Given this list of marker genes FANCG, PTEN, RFWD3, DLL4, RAD51, GLMN, RASA1, FANCL, RBPJ, COL3A1, RAD51C, BRCA2, AKT1, GUSB, FANCE, FANCB, BRCA1, FANCF, UBE2T, COL5A1, MAD2L2, CAV1, PIK3CA (NCBI Gene Id 5290), PALB2 (NCBI Gene Id 79728), ARL6IP6, COL1A1, XRCC2, EPHB4, ADAMTS3, AGGF1, GNA11, CCBE1, ACVRL1, COL5A2, EOGT, CBS, FANCD2, ENG, FAT4, TEK, FANCM, SLX4, GNAQ, FANCI, KRAS, NOTCH1, GDF2, DOCK6, BRIP1, SMAD4, FANCA, ERCC4, IL6, FANCC, ARHGAP31, here is a description of the gene set: Arteriovenous malformation species: Homo sapiens Human Gene Set: HP_ARTERIOVENOUS_MALFORMATION An anomalous configuration of blood vessels that shunts arterial blood directly into veins without passing through the capillaries.